Given this list of marker genes MED23, TNFRSF14, CCR6, CCL4, GCSAML (NCBI Gene Id 148823), ITGB3, DEFA1B, PYCARD, CD200R1, ZAP70, CD200, WNT5A, F11R, APP, PIK3CG, GCSAM (germinal center associated signaling and motility), S1PR1, S100A7, ADTRP, CCL26, XCL1, GPR183, RIPOR2, CXCR3 (NCBI Gene Id 2833), OXSR1, CRTAM, CXCL10, MADCAM1, MSMP, JAM2, P4HB, DEFA4, STK10, MIA3, CH25H, ADAM17, DOCK8 (NCBI Gene Id 81704), ASCL2, GBA1, EXT1, CCR7, KLRK1, CCL7, CXCL16, CCL3, MSN, STK39, AIRE, LRCH1, FUT4, DEFA1, ITGAL, PLEC, CXCL11, AIF1 (allograft inflammatory factor 1), CORO1A, SLC12A2, MYO1G, PADI2, SLC8B1, SPN, ABL1 (ABL proto-oncogene 1, non-receptor tyrosine kinase), FADD, PTK2B, IL27RA, PIK3CD, FUT7, ICAM1, KLRC4-KLRK1, TMEM102, LRP12, CCL2, CCL20, ECM1, APOD, ADAM10, CD99L2, GAS6, CXCL13 (C-X-C motif chemokine ligand 13), LGALS9, CD69, ITGA4, TBX21, WASL, CXCL12, GATA3, CCL21, GPR15LG, CKLF, CCR2, RIPK3, XG, GNAI1, SAA1, ARTN (artemin), CD99, RHOA, SPNS2, HSD3B7, CRKL, RET, SELENOK, WNK1, TNFSF14, CX3CL1, CCL5, ADAM8, GPR15, CRK, AKT1 (AKT serine/threonine kinase 1), ABL2, CYP7B1, NEDD9, ITGB7, here is a description of the gene set: Human Gene Set: GOBP_LYMPHOCYTE_MIGRATION The movement of a lymphocyte within or between different tissues and organs of the body. studied in species Homo sapiens